Given this list of marker genes KIF3B, TMEM67, MED12, WDR19, IFT56, here is a description of the gene set: studied in species Homo sapiens Increased diameter (caliber) of intrahepatic bile ducts (bile ducts that transport bile between the Canals of Hering and the interlobar bile ducts). Intrahepatic bile duct dilatation Human Gene Set: HP_INTRAHEPATIC_BILE_DUCT_DILATATION